The following is a description of a gene set: Regulation of lineage potential and transcriptional priming by Ikaros. New insight is provided into a bivalent regulation of lineage priming in the HSC and its lympho-myeloid restricted progeny the LMPP by the lymphoid lineage-determining factor Ikaros Whereas Ikaros is responsible for the activation of a cascade of lymphoid expression programs and for the establishment of lymphoid potential from the HSC to the LMPP it is also responsible for the repression of stem cell and erythroid genetic programs that are incompatible with further lineage restrictions emanating from the LMPP Genes up-regulated in IKZF1 knockout: hematopoietic stem cells versus granulo-monocyte progenitors. species: Homo sapiens Human Gene Set: GSE15330_HSC_VS_GRANULOCYTE_MONOCYTE_PROGENITOR_IKAROS_KO_UP from publication Ng SY, Yoshida T, Zhang J, Georgopoulos K (PMID 19345118), and this is the list of marker genes: ZDHHC20, KIF3A, BLCAP, ULK1, DNAJC3, LENEP, RELL1, BIN1, B4GALT4, SYNGR1, TMEM109 (NCBI Gene Id 79073), RABAC1, AQP3, POLR2E, LRIG1, SYNCRIP, SMARCA1, ATP11B, ACSL4, RASA2, L1CAM, KDM3A, PIGM, KRTCAP2, TMEM184B, POLD4, HYCC2, ATE1, GLUL, SACS, NUBP2, ARHGEF10L, PHF13, IL2RA, NEK4, CARD19, CUX1, EN1, PLEKHF2, PROKR1, TRIP11, NEK6, LAMP2, TGFBR1, PTPRJ, TIMP2, PLP2, WDFY2 (NCBI Gene Id 115825), PDE4DIP, BCL6, EEIG1, GNGT1, ANXA3, IL24, CAPZA2, GRN, SPSB3, ORMDL2, IFNAR2, FLNB, GADD45G, PRPS1, SNTB2, ITPA, CERS5, CDC16, CXCR6, FXYD5, CTNNBIP1 (NCBI Gene Id 56998), PTDSS2, PHACTR2, CPEB2, RAB6A, RBM12, GABBR1, LMNA, MGAT2, CD5L, STAT5B, ARHGAP12, RUNX3, JMY, RAD52, NUP210, SLC25A19, PLOD2, SKIL, SYT3, ATOSB, IL17RA, ATP6V0A1, UBQLN1, LGMN, FAM50A, SLK, MTMR7, IFI30 (IFI30 lysosomal thiol reductase), IL1R1, SMPD2, SERINC1, PXN, WWOX, TEX56P, MARCHF2, JDP2, SLC44A1, HAUS2, CHMP5 (NCBI Gene Id 51612), GGA2, IGHG1, PRX, STRN3, ABHD17C, CYP11A1, PDCL3 (phosducin like 3), CFAP36, PLOD3, CCL20, EGR2, TAMALIN, ADAM21, CREB3L2, RAB4A, POSTN, MYD88, RIOK3, GRHL1, SLCO3A1, DIPK1B, IL9, MIEN1, SYP, NCMAP, ARID5B, RPS6, COG6, IL10, PLSCR3, RBPJ, PLA2G12A, LGALS1, DDIT4, GMEB1, N4BP1, ZNFX1 (zinc finger NFX1-type containing 1), VMP1, GEM, SEMA7A, PM20D1, P2RY6, CRYBG1, ANGPTL2, BATF, TMX1, PA2G4, PABIR1, RUFY2, RPLP0, SEPSECS, LDLRAD4, FES, MAN1A2, TSPAN5 (tetraspanin 5), KIF3B, LPP, SOCS1, IGFBP4, CHM, ALPK2, RAB20, TTC39B (tetratricopeptide repeat domain 39B), CTSW, MIDN (midnolin), SURF6, WBP1L, STARD8, ARHGAP39, FJX1 (NCBI Gene Id 24147), RGCC, TSPAN14 (NCBI Gene Id 91090), GEMIN8, PUM1, PPME1, GDPD1, CUL7, WDR20, SIAH1, TRPS1, TRIM32, ZFP2, OSBPL1A, TFRC, YAF2, LPAR4, MARK4, FURIN, RABGEF1, KRAS, GLIPR2 (GLI pathogenesis related 2), DIAPH2